The following is a description of a gene set: Any process that modulates the frequency, rate or extent of any cellular process that depends upon or alters the actin cytoskeleton. Mouse Gene Set: GOBP_REGULATION_OF_ACTIN_FILAMENT_BASED_PROCESS studied in species Mus musculus, and this is the list of marker genes: Myo1c, Fermt2, Cav1, Ilk, Capn10, Gba2, Capza3, Baiap2, Tnnc1, Rapgef3, Kank1, Arhgap40, Washc5, Crk, Tsc1, Prkn, Mtor, Naa80, Ccl27a, Dixdc1, Hip1r, Bst1, Trpm2, Rgs4, Arap3, Arhgef18, Bcas3, Limk1, Gata4, Taok2, Washc4 (WASH complex subunit 4), Siglec15, Plek, Ssh3, Add1, Lima1, Kirrel1, Akap6, Cdc42, Capza1, Pecam1, Flii, Met, Arhgef19, Inppl1, Nedd9, Evl, Capza1b, Arhgef16, Add2, Fer, S100a10, Tpm1, Dsc2 (desmocollin 2), Arhgap44, Arhgef5, Tgfb1, Ctnna2, Bbs4, Fam107a, Mtss1, Alms1, Ppm1f, Rhobtb2, Pak1, Carmil3, Dbn1, Tenm1, Fmn1, Atp2a1, Tac1, S1pr1, Arpin, Brk1, Cdk5r1, F11r, Nck1, Lmod1, Sptan1, Slit2, Atp1a1, Carmil2, Edn1, Cyfip2, Pfn2, Rala, C9orf72, Tmod2, Arpc2, Arfip2, Epha3, Mtpn (myotrophin), Odam, Was, Washc1, Rnh1, Arhgap35, Dnai3, Tjp1, Sh3pxd2b, Tmod3, Wasf2, Pde4d, Pfn1, Atp1a2, Ankrd23, Acta2, Ptger3, Frmd7 (NCBI Gene Id 665849), Kcnj2, Cracd, Hax1, Cdc42ep5, Rgcc, Swap70, Naa20 (NCBI Gene Id 99228), Arfgef1, Nox4, Celsr1, Nf2, Limch1, Akap9, Myo3a, Rnd3, Bag4, Clec2i, Fchsd2, Pdxp, Iqgap2, Smad4, Ccl11, Shroom2, Smad3, Wnt4, Rac2, Phldb2, Prex1, Shank3, Alox15, Kank3, Arap2, Rhof, Pfn5, Cacna1c (calcium channel, voltage-dependent, L type, alpha 1C subunit), Sh3bp1, Efna5, Arf6, Epha5 (Eph receptor A5), Pard3, Fzd10, Cyria, Adrb1, Avil, Tgfbr1, Dlc1, Baiap2l1, Arhgef26, Pdpn, Fhod3, Ptk2b, Cfl2, Hcls1, Taok1, Esam, Tesk1, Pdlim4, Cfl1, Arf1, Arpc5 (NCBI Gene Id 67771), Cdc42ep4, Ccdc88a, Kiss1r, Strit1, Prkd1, Gm14137, Prkce, Ccl26, Ccl24, Pdgfrb, Gmfb, Synpo, Rhod, Pak2, Mkks, Vasp, Specc1l, Rangrf, Plekhg2, Cdc42ep3, Lrp1, Gmfg, Myadm, Cgnl1 (NCBI Gene Id 68178), Ppp1r9a, Wasf3, Hrg, Prox1, Pycard, Itgb3, Nckap1l, Braf, Ttc8, Kank2, Tacstd2, Sptb, Itgb1bp1, Washc3, Daam2, Wasf1, Ccl21a, Carmil1, Cyfip1, Abracl, Capn1, Arap1, Shank1, Tmeff2, Vill, Cdc42ep2, Xirp2 (xin actin-binding repeat containing 2), Myo1f, Trpm4, Pln (NCBI Gene Id 18821), Ccl21f, Trim27, Lmod2, Zeb2, Pik3ca (NCBI Gene Id 70742), Cdc42ep1, Actn2, Il1a, Cnn2, Gja5, Sema5a, Akap13, Spta1, Nrp1, Sumo1, Myoc, Inpp5k, Ssh1, Abl1, Hdac2, Map3k1, Fhod1 (NCBI Gene Id 234686), 4930544G11Rik, Clasp2, Abitram, Cttn, Mlst8, Vangl2 (VANGL planar cell polarity 2), Synpo2, Capza2, Arpc3, Hcn4, Rdx, Mylk3, Dstn, Myo3b, Abi2, Twf1, Sptbn1, Neb, Ryr2, Magel2, Cdk10, Csrp3, Lmod3, Wdr1, Coro1b, Twf2, Stmn1, Eps8, Myh7b, Pik3r1, Tacr1, Tmod4, Flna, Epha1, Rock2, Arhgap6, Grhl3, Tmsb15b2, F2rl1, Ccl21e, Mef2c, Rnd2, Ccl21d, Sorbs3, Actg1, Plekhh2, Ptger4 (NCBI Gene Id 19219), Ank2, Id1, Pam, Rac3, Stc1, Rhoc, Rasa1, Fgr, Arfip1, Synpo2l, Capg, Rhobtb1, Rnd1, Casq2, Frmd6, Pxn, Ppfia1, Dmtn, Washc2, Pick1, Rac1, Coro2b, Scin, Add3, Fxyd1, Ccl21b, Actr3, Pkp2, Jam3, Dsg2, Cacna1h, Gsn, Prkcd, Vil1, Tmsb4x, Icam1, Sdc4, Coro1a, Adcy10, Cyrib, Tlr2, Arhgef10l, Asap3, Nckap1, Baiap2l2 (NCBI Gene Id 207495), Hck, Atp2a2, Bmp10, Snx9, Ppm1e, Cd47, Wmp, Nck2, Tnnt2, Jup, Arhgap28, Cit, Gja1, Csf1r, Myh9, Fchsd1, Clasp1, Rhoa, Ep300, Csf3 (colony stimulating factor 3 (granulocyte)), Sri, Serpinf2, Dapk3, Fgf13 (fibroblast growth factor 13), Rhpn2, Grb2 (growth factor receptor bound protein 2), Lats1, Stau2, Arhgef15, Dsp, Prkcq, Arhgap18, Pfn3 (NCBI Gene Id 75477), Wnt11, Dlg1, Cd2ap, Tmsb15l (NCBI Gene Id 399591), Bst2, Nphs1, Pik3r2, Arhgap17, Gpm6b, Pak3, Adora1, Eln, Ssh2, Rhog, Dbnl, Gm28729, Mfn2, Scn5a, Smim22, Nos1, Apoa1, Fscn1, Kank4, Rhpn1, Bin1 (NCBI Gene Id 30948), Tmod1, Mylk2, Ctnna3, Tgfb2, Ccn2, Lpar1, Gpr65, Arhgef10, Capzb, Rictor, Ngef, Arpc5l, Ect2, Whamm, Cotl1 (coactosin like F-actin binding protein 1), Slc4a2, Rock1, Svil, Ap1ar, Cx3cl1, Hras, Cav3, Tgfb3